The following is a description of a gene set: An immune response directed against a previously encountered antigen, being quicker and quantitatively better compared with the primary response. species: Homo sapiens Human Gene Set: GOBP_ADAPTIVE_IMMUNE_MEMORY_RESPONSE, and this is the list of marker genes: TNFRSF14, CD70, CD160, EBAG9, CD27, CD81, IGHE